Given this list of marker genes Irgm1, Fnip1, Trex1, Irgm2, Grn, Becn1, Flcn, Mcoln1, Igtp, Mtor, Tmem106b, Ppp3cb, Laptm4b (NCBI Gene Id 68111), here is a description of the gene set: Any process that modulates the frequency, rate or extent of lysosome organization. species: Mus musculus Mouse Gene Set: GOBP_REGULATION_OF_LYSOSOME_ORGANIZATION